Given this list of marker genes DDR2, SERPINH1, COLGALT2, PLOD3, PXDN, PLOD2, COL1A2, SCX, LOX, MIR29B1, ADAMTS14, ATP7A, P3H4, COL11A1, BMP1, VIPAS39, ADAMTS3, COL3A1, COL6A1, AEBP1, COL11A2, OPTC, EXT1, LOXL2, GREM1 (gremlin 1, DAN family BMP antagonist), LOXL3, COMP, FMOD, FOXC2, ADAMTS7, DPT, TGFB2, FOXC1, RB1, LUM, COL5A1, COLGALT1, EFEMP2, TNXB, LOXL1, COL14A1, TLL2, CRTAP, ADAMTS2 (NCBI Gene Id 9509), SERPINF2, TGFBR1, ANXA2, P3H1, ERO1A, ANTXR2, FKBP10, COL5A2, COL2A1, EMILIN1, VPS33B, LOXL4, ADAMTS19 (NCBI Gene Id 171019), COL1A1, NF1, SFRP2, COL12A1, PLOD1, P4HA1, CYP1B1, ADAMTS12, COL5A3, TLL1, MMP11, SELENON, P4HA3, CHADL, here is a description of the gene set: Any process that determines the size and arrangement of collagen fibrils within an extracellular matrix. Human Gene Set: GOBP_COLLAGEN_FIBRIL_ORGANIZATION species: Homo sapiens